The following is a description of a gene set: Human Gene Set: GOBP_ENDOCHONDRAL_BONE_MORPHOGENESIS species: Homo sapiens The process in which bones are generated and organized as a result of the conversion of initial cartilaginous anlage into bone., and this is the list of marker genes: CER1, RARA, NPR2, COL1A1, POR, NPPC, DLX5, FGF18, IHH, INPPL1, CBS, ALPL, FOSL2, THBS3, CSGALNACT1, IFT80, RARB, MATN1, SMPD3, SCX, EXT1, RARG, ENSG00000274276, NAB1, PEX7, SOX9, TGFBR2, NAB2 (NGFI-A binding protein 2), TRPV4 (transient receptor potential cation channel subfamily V member 4), COL27A1, SHOX2, MMP14, MMP16, HOXA11, COMP, AXIN2, EXT2, POC1A, RUNX2, BMP6, GHR, BMP4, FGFR3, COL13A1, MMP13, ATF2, FOXC1, BMPR1B, MEF2C, TSKU, COL2A1, BPNT2 (3'(2'), 5'-bisphosphate nucleotidase 2), ZMPSTE24, BMPR2, TMEM119, GALNT3, COL3A1, PHOSPHO1, TRIP11, SERPINH1, STC1